The following is a description of a gene set: Mouse Gene Set: GOMF_RACEMASE_AND_EPIMERASE_ACTIVITY_ACTING_ON_CARBOHYDRATES_AND_DERIVATIVES Catalysis of a reaction that alters the configuration of one or more chiral centers in a carbohydrate molecule. species: Mus musculus, and this is the list of marker genes: Gfus, Dse, Fuom, Galm, Glce, Gne, Renbp, Dsel, Rpe, Gale